The following is a description of a gene set: Human Gene Set: FAN_EMBRYONIC_CTX_ASTROCYTE_1 studied in species Homo sapiens from publication Fan X, Dong J, Zhong S, Wei Y, Wu Q, Yan L, Yong J, Sun L, Wang X, Zhao Y, Wang W, Yan J, Wang X, Qiao J, Tang F (PMID 29867213), and this is the list of marker genes: PAX6, LINC00943, HES4, ANOS1, AGT, MLC1, SLC1A3, FOXG1, GABRB1, MRC2, EZR, RGS20, ALDOC, EEPD1, TSKU, HEY1, ADCYAP1R1, CDH4, HTR2A, SOAT1, FADS2, TNC, EFHD2, CSDC2, MMP28, ADORA2B, PEA15, PAQR8, CXCR4, FRMD4A, LAMP5, LRP4, IFI44L, NCAN, LSS, FABP7, OLFM2, OAF, VEPH1, SPARCL1, ADGRV1, PLEC, SLCO1C1, FAM107A, LPCAT1, EMID1, SFXN5, RAMP3, DOK5, NOG (NCBI Gene Id 9241), GRM3, SYPL1, LGALS3, C1QTNF3, CXCL14, CYB5A, ID2, NPNT, LRRC10B, LRRC3B, LYN, ANGPTL1, GFAP, SIRPA, TM7SF2, TCIM, CBS, CPNE5, ID1, DIO2, DCN, ID3, GPX3, CHRDL1, GALNT16, CDC42EP4, BTBD17, PRSS35, PLAGL1 (NCBI Gene Id 5325)